The following is a description of a gene set: Human Gene Set: GOMF_1_ACYLGLYCEROPHOSPHOCHOLINE_O_ACYLTRANSFERASE_ACTIVITY Catalysis of the reaction: 1-acyl-sn-glycero-3-phosphocholine + acyl-CoA = phosphatidylcholine + CoA. species: Homo sapiens, and this is the list of marker genes: LPCAT1, PRDX6 (peroxiredoxin 6), LPCAT3, MBOAT2, LPCAT4, LPCAT2, MBOAT1, TAFAZZIN